Given this list of marker genes MBD4 (NCBI Gene Id 8930), CAV1, POLR3H, WNT7A, SLC37A4, NPM1, PIK3CA, BMPR1B, PEX1, LEP, NDNF, FGFR2, GAD1 (NCBI Gene Id 50977), BBS5, IL17RC, CYP19A1, FDXR, SALL1, DNAJC30, HYMAI, MMP14, ATR, GLI1, TBX3, VAC14, MID1, GABRD, RAD51, FANCA, GNRHR, SDHB, DMRT1, TYMS, PANX1, HNF1A, CDKN2A, RFWD3, DKC1, GNAS, BBS7, RAB3GAP2, SKI, SPIDR, NIPBL, HFM1, METTL27, NDN, PORCN, MYRF, MOGS, PLIN1, SOX3, DYNC2LI1, DVL3, MESP2, PAX3, ZFPM2, KAT6B, PDGFRL, SLX4, BUB1B, PPP2R1A, SOHLH1, TRAIP, BAZ1B, CHRNG, ZFTA, TRIM32, COQ6, HS6ST1, IRF6, RAD21, DHCR7, DCC, POLD1, JMJD1C, STRA6, MSH5, NSD2, NF2, SDHD, RAD51D, CPLX1, MAMLD1, MMP23B, CCNQ, NUP107, USB1 (NCBI Gene Id 79650), CEP57, COL1A1, SEC23B, WNT10A, MSH3, SRD5A2, HESX1, RAD54B, ERAL1 (NCBI Gene Id 26284), AGPAT2, NPHP1, CTC1, PEX13, LUZP1, CEP290, UBE4B, NPAP1, RNU12, TBC1D20, FIG4, PAX6, MT-CYB, FLCN, KRAS, PI4KA (phosphatidylinositol 4-kinase alpha), ARHGAP31, TGFBR2, ITGA8, DYNC2I1, PTPN11, TBX6, BAX, STX1A, SMARCB1, PLAGL1, KEAP1, TWIST2, CEP152, FREM1, ORC4, JAK3, POU6F2, GTF2I, SF3B4, WT1, TBX1, WDR35, TUBB8, CD96, ALG9, SEMA3A, SOX9, CHEK2, RSPO2, WNT9B, KISS1, MSH6, FGF17, STOX1, RNF43, ACTB, TRPV6, CXCR4, MCC, USF3 (upstream transcription factor family member 3), FANCC, PALB2, TERC, PIGN, DVL1, ECEL1, PEX10, LMNA, ZMYM2, LHB (luteinizing hormone subunit beta), RERE, PWRN1, IFT80 (intraflagellar transport 80), SUFU, FOXE1, PALLD (palladin, cytoskeletal associated protein), PMS2, BSCL2, PSMC3IP, HCCS, TACR3, COL5A2, UFD1, IFT74, KLLN, MCM8, TAF6, PPP1R12A, PEX19, BBIP1, TSC1, GNB2, CIDEC, EVC, FANCI, RAB18, STAG3, NAB2, GTF2IRD2, RFC2, WRN, FANCE, BUB3, NSMF, DIS3L2, BMPR1A, UBR1, ALMS1, CYB5A, WWOX, LETM1, RAC3, CCDC28B, TMEM270, RTEL1, RSPO1, SOX10, AXIN1, MUTYH, FLI1, TRAF3IP2, FLT1, CTNNB1, BBS2, FREM2, PRDM16, HDAC8, PLA2G2A, SETBP1, CORIN, EVC2, OPCML, CAPN15, PHKA2, KIF14, PMM2, SCLT1, RIPK4, TRIM28, SLC6A17, DCAF17, PCNT, GREB1L, ESCO2 (NCBI Gene Id 5951), IL17F, PLG, FOS, CYP11B1, PRLR, LIMK1, LZTFL1, FANCD2, MAD2L2, TALDO1, SMAD2, PEX2, FOXL2, EFEMP1, WDPCP, SPECC1L, FGF20, BBS12, PHGDH, POLE, OCA2, NOP10, PRKN, NDUFB11, MKS1, SOX11, HSD3B2, PATL2, CDH1, POLR1D, AKT1, NR5A1, ATM (ATM serine/threonine kinase), TRIP13, LRP2, GATA4, TNXB, WNT4, BRIP1, PWAR1, BARD1, SMC1A (structural maintenance of chromosomes 1A), IDH2, B3GLCT, IL10RB, FGF10, WEE2 (WEE2 oocyte meiosis inhibiting kinase), DYNC2H1, BRCA1, PARN, MKRN3, COL7A1, NDP, PHKB, PPARG, DLC1, POR, NXN, ROR2, TGFB3, MED25, ERBB2, LMNB2, SNRPN, TAC3, WNT3, AKT2, ITPR1, BBS4, ARID1B, PHKG2, CYP17A1, MAP3K1, NR3C1, CHD7, MTM1, TGFB2, PROK2, MSX1, HOXA13, FKBP6, GATA2, GREM1, NTHL1, TTC8, SPRED1, ATIC, HYLS1, CYP11A1, PEX16, FANCF, FRAS1, RAD50, FGFRL1, EIF4H, PTCH1, IL17RA, CBX2, CDC6, SIM1 (SIM bHLH transcription factor 1), PRKACB, DICER1, SEC24C, SMAD3, TP63, SMAD4, RAD51C, PRKAR1A, PRKACA, FANCL (NCBI Gene Id 55120), BNC1, KIF7, CLIP2, BCOR, AURKA, SLC35A2, LIPE, TINF2, TBX15, THOC6, RIPPLY2, RET (NCBI Gene Id 5979), CASZ1, LZTR1, H19, NBN, CFAP418, MINPP1, POC1A, MYH3, TP53, VPS37D, WRAP53, PDPN, CCDC141, BUB1, NHLH2, WNT7B, SETD2, GLI3, BRAF, TSC2, CDC73, UBE3B, DACT1, HARS2, BRCA2, ZEB2, PLAAT3, FH, HNF1B, HPS6, WDR11, STK11, ESR2, IL17RD, BBS10, CDC45, MRPS22, STAT6, MAD1L1, BBS9, ISL1 (NCBI Gene Id 3670), ADH5, ZPR1, GRIP1, SRC (SRC proto-oncogene, non-receptor tyrosine kinase), XRCC2, COL4A6, FGFR1, MLH1 (mutL homolog 1), IPO8 (importin 8), CDT1, NOBOX, SMARCA2, SLC25A24, CLEC7A, PEX5, GFRA1, EP300, ANTXR2, BMP15, PTPRJ, PEX14, LEPR, UBE2T, RARB, ORC1, HERC2, TCOF1, COMT, MKKS (NCBI Gene Id 8195), PIGG, LIG4, RPS20, PEX26, FEZF1, TCTN3, PROKR2, FANCG, SPEN, ORC6, REST, ANOS1, NR2F2, DYNC2I2, DHCR24, PEX12, DDB1, SCAPER, MSH4, PTPN12, SDCCAG8, POLR1B, PEX11B, PEX3, VAMP7, SALL4 (spalt like transcription factor 4), FSHR, MLH3, SPINT2, AXIN2, PEX6, SNORD116-1, CAVIN1 (caveolae associated protein 1), ERCC4, MSH2, NELFA, MAGEL2, PTEN, SEMA3E, MAB21L1, POLR1C, IFT27, NSUN2, SMC3, NRAS, ESR1, EPCAM, CHRM3, DLL3, COL5A1, AR, HSPG2, NCF1, SDHC, NR0B1, CTCF, EWSR1, PDE11A, SMCHD1, INTU, MYC, COL4A5, SPRY4 (NCBI Gene Id 81848), TGFBR1, FGFR3, FIGLA, HNRNPR, DUSP6, GTF2IRD1, DHX37, LONP1, LARS2, FLRT3, DHH, ZSWIM7, BRD4, SNORD115-1, NIN, RBM8A, APC, TBL2, PIK3R1, CCND1, IFT172, F7 (coagulation factor VII), TBX4, KCNAB2, RELA, GPC3, OFD1, FGF8, FANCM, TLR2, PMS1, COX7B, NHP2, FANCB, MMP2, SRY, HIRA, RAB3GAP1, MRE11, BUD23, PTCH2, SEMA4A, HOXD13, GATA3, RECQL4, FZD2, HROB, TXNDC15, COL3A1, ARL6, GP1BB, C14orf39, IDH1, TOE1, PDE4D, MDM2 (NCBI Gene Id 84825), TERT, RREB1, MNX1, RABL3, CDKN1B, CTBP1, LFNG, PRKCZ, CLPP, KISS1R (KISS1 receptor), GNRH1, HES7, RPS6KA3, PPP2R3C, ARVCF, FOXF1, GMNN, CEP19, BBS1, ELN, WNT5A, INSR, here is a description of the gene set: Abnormality of the female genitalia species: Homo sapiens Human Gene Set: HP_ABNORMALITY_OF_THE_FEMALE_GENITALIA Abnormality of the female genital system.